Given this list of marker genes TH, COMT, AANAT, DBH (dopamine beta-hydroxylase), PAH, DDC, GAD1, PNMT, HDC, CHAT, TPH1, ASMT (acetylserotonin O-methyltransferase), MAOA, ACHE, GAD2, here is a description of the gene set: Human Gene Set: WP_BIOGENIC_AMINE_SYNTHESIS Biogenic amine synthesis species: Homo sapiens